Given this list of marker genes SCARB1, GAS6, ICAM1, DPP4, ACE2, HSPD1, BPIFA1, INHBB, LRRC15, LTF, CLEC4M, HSP90AB1, CD209, NECTIN2, TMPRSS2, here is a description of the gene set: The attachment of a symbiont to its host via either adhesion molecules, general stickiness, or other mechanisms. The host is defined as the larger of the organisms involved in a symbiotic interaction. species: Homo sapiens Human Gene Set: GOBP_ADHESION_OF_SYMBIONT_TO_HOST